The following is a description of a gene set: This event has been computationally inferred from an event that has been demonstrated in another species.<p>The inference is based on the homology mapping from PANTHER. Briefly, reactions for which all involved PhysicalEntities (in input, output and catalyst) have a mapped orthologue/paralogue (for complexes at least 75% of components must have a mapping) are inferred to the other species. studied in species Mus musculus electronically inferred by orthology from the curated human pathway Reactome Pathway: RHOG GTPase cycle part of: RHO GTPase cycle, and this is the list of marker genes: Epha2 (NCBI Gene Id 13836), Itsn1, Vrk2, Lbr, Mcam, Prex1, Depdc1b, Ndufs3, Esyt1, Mpp7, Vav1, Arhgdib, Lamtor1, Cav1, Letm1, Vangl1, Dock5, Hspe1, Lman1, Rab7, Ktn1, Dock2, Plekhg3, Ndufa5, Arhgdig, Ophn1 (oligophrenin 1), Ankle2, Emd, Pak4, Cdc42, Pgrmc2